The following is a description of a gene set: The phosphorylation by a protein of one or more of its own amino acid residues (cis-autophosphorylation), or residues on an identical protein (trans-autophosphorylation). studied in species Mus musculus Mouse Gene Set: GOBP_PROTEIN_AUTOPHOSPHORYLATION, and this is the list of marker genes: Fgfr4, Eif2s1, Ppp2r5b, Pikfyve, Tssk4, Cad, Mtor, Mos, Tom1l1, Ttk, Pdgfra, Ddr1, Kit, Nlk, Fyn, Ephb4, Flt4, Ddr2, Tyro3, Cav1, Dyrk1a, Trim24, Fgfr2, Clk1, Chp1, Stk10, Stk4, Epha8, Camk2g, Syk, Mre11a, Map3k20, Gsk3b, Map3k12, Zap70, Sik2, Irak1, Ros1, Prkca, Csnk2a1, Insrr, Aurkc, Hipk4, Iqgap1, Mark3, Nek2, Map3k13, Nbn, Melk, Ulk3, Grem1, Wnk3, Fgr, Prkd2, Map3k11, Tesk1, Tnk1, Stk33, Chek2, Oxsr1, Stk17b, Mvp, Ptk2b, Myo3b, Fer, Stk11, Lrrk2, Map2k2, Cdkl5, Ptk2, Myo3a, Peak1, Rap2a, Egfr (NCBI Gene Id 13649), Rad50, Csf1r, Ntrk1, Stk26, Mylk2, Stk16, Ephb1, Gpnmb, Mink1, Hck, Jak2, Txk, Prkd1, Stk25 (NCBI Gene Id 98522), Adipoq, Ripk3, Prkaca, Src, Vegfa, Lck, Ulk1, Stk39, Alk (NCBI Gene Id 11682), Eef2k, Abl1, Ngf, Smg1, Pdgfrb, Lyn, Ulk2, Mapk15, Tssk2, Map3k3, Atp13a2, Irak2, Ppp2ca, Aatk, Pdgfb, Wnk2, Slk, Camkk2, Ppp2r5d, Mapkapk5, Enpp1, Pak2, Nrg1, Camk2a, Map3k9 (mitogen-activated protein kinase kinase kinase 9), Grk5, Mark2, Irak3 (interleukin-1 receptor-associated kinase 3), Pask, Pink1, Ern1, Ntrk2, Ltk, Ctnnd1, Dapk3, Trpm7, Gfra2, Cdk12, Stk24, Eif2ak3, Met, Tnik, Ripk1, Flt1, Mob1b, Flt3, Rap2b, Ptprc, Epha1, Sik1, Pim1, Eif2ak4, Clk3, Nek10, Clk4 (CDC like kinase 4), Lmtk2, Clk2, Mapk3, Eif2ak1, Errfi1, Nek6, Eif2ak2, Rassf2, Pak1, Pdgfa, Vrk2, Trim28, Ephb3, Jun, Kdr, Camk2d, Atr, Srms, Bmx (BMX non-receptor tyrosine kinase), Fes, Epha7, Acvr1b, Epha4, Brd4, Htatip2, Prlr, Vrk1, Obscn, Insr, Dapk1, Rap2c, Grk1, Ddx3x, Igf1r (insulin-like growth factor I receptor), Map4k1, D1Pas1, Camk2b, Erbb4, Fgfr1, Tnks1bp1, Uhmk1, Taok3, Vegfc, Nlrp12, Prkx, Atm, Riok2 (NCBI Gene Id 73706), Mak, Ptk6